Given this list of marker genes JPH4, OAT, GPR148, OR2D3, CASP3, OR12D3, OR10K1, OR2AP1, SPG11, OR56A5, OR13C6P, RAG1, ESPN, GALR2, MYO15A, FKBP1A, TMPRSS3, OR1L6, NR2F6, CLRN2, OR4P4, NRXN3, TAS2R50, TIFAB, GPR179, OR8U1, OR10J1, EYS, NMU, PRPH2, SYT10, OR2S2, NDRG4, CTNS, OR10X1, OR13C7, FKBP1B, OR4F6, B3GNT2, NLGN4Y, OR51C1P, OR2T12, OR52R1, OR8G1, PAX6, OR4N2, DAW1, OPN4, OMP, LGMN, FGF13, RGS16, SPAG16, PVALEF, OR14K1, BEST2, RGR, KAT2A, OR8U8, OR4C46, GMPPA, OR7D4, OR6B2, OR10AC1, CIC, VPS13B, PAX2, SLC24A1, GRIA1, BRSK1 (NCBI Gene Id 84446), CSMD1, FIG4, DCTN1, CHRNA5, OR6N1, RDH11, LARGE1 (NCBI Gene Id 9215), OR1S2, OR52M1, ASIC3, GNAT1, VN1R17P, CEBPA, OR1F12P, OR8J2, EFEMP1, CACNA1F, TNNI1, RAB3GAP1, SLC1A3, MANF, OR13C3, NPY2R, KCNK9, TENM4, OR56A4 (NCBI Gene Id 79271), SOD1, OR4K13, YTHDF1, HIF1A, KIAA0319, CLN3, CACNG2, FGFR1, OR11H2, ELMOD3, GPER1, CRX, OR6C6, GCH1, PIEZO2, OR2T35, DRD1, OR6C65, GRIN2A, OR9Q2, SCN4B, PCARE (NCBI Gene Id 388939), OR52A4P, AMFR, RBP3, ODAD4, NTRK1, ARR3, OR52E6, OR12D2, ALDH7A1, THRB, MECP2, CRYZ, OR6N2, NPAS4, FZD4, OR6Y1, OR4E2 (olfactory receptor family 4 subfamily E member 2), OR9G1, OR8A1, GSK3B, GRIN2B, SPG21, OR51B5, OR4F16, BLOC1S6, TIMM8B, POU3F4, RGS4, OR2B6, WHRN, ATXN7, MRGPRX2, C12orf57, HERC1, TAS2R46, OR5A2, SYNJ1, DNAAF3, KCNK4, OR7A5, OR5AR1, PRKAR2B, CHRNB4, ADRA2A, OR9A2, TUSC3, SLC52A3, MEF2C, OR52I2, NCMAP, OTOA, OR11L1, NDUFB9, RCAN2, TUBA1A, SCN4A, EIF4EBP2 (eukaryotic translation initiation factor 4E binding protein 2), OR52E2, NOS3, OR4A16, NTAN1, ITPR1 (NCBI Gene Id 619543), NCSTN, NXNL2, DNAJB6, GUCA1ANB-GUCA1A (GUCA1ANB-GUCA1A readthrough), GSTO1, ATF6, OR2W3, IGLON5, JPH3, TRPV1, SSH1, REST, OR4A4P, ARL6, PLCB2, S100B, OR56A3, OR51T1, UNC13B, CYP4V2, CRB2, GPI, PDC, DICER1, LOXHD1, KCNJ8, GABRB3, SHANK3, ITGB1, ADARB1, NSUN5, FGF12, OR2A12 (NCBI Gene Id 81432), ATP1A2, GPR155, REEP2, OR13C2, OR51Q1, OR5AU1, FAM161A, REEP6, ELP6, GRIN1, SLURP1, GJB4, TMEM108, RGS9 (regulator of G protein signaling 9), OR2T3 (olfactory receptor family 2 subfamily T member 3), DHRS3, OR5AS1, OR2V1, KCNMB4, ANKFN1, ACP3, CASQ1, CABP1, RPS6KA2, GJC1, KCTD16, OR2T10, MYO1A, OR14J1, OR4A8, GRIK2, OR2J2, BEGAIN, GNAT2, HMCN1, MYC, OR5H1, USH2A, SLC6A1, BRAF, DNAAF4, PIGR, TNFRSF1B, SCNN1A, DOP1B, HPS1, CA6, FZD2, ESPNL, OR5B12, SLC1A4, DRAM2, PPEF2, TMEM63B, DNAH9, NF1, TNR, OR14I1, SPX, KCNQ4, OR8U9, OR51E1, PHF24, OR2M3, PPP3CB, ADORA1 (adenosine A1 receptor), CABP4, OR6C75, ATPSCKMT, LILRB2, ALOXE3, OR4M2B, TAS2R20, GIP, NIPSNAP1, OR4A5, VLDLR (NCBI Gene Id 7436), PRKAR1B, CDKN2D, TAS2R16, ATP8A2, GLP1R, CHRM1, VAX2, C1QL1, USP53, TAS2R38, TMEM87A, KCNA1, TTC8, OR5A1, RP2, P2RX2, BLOC1S4, CPEB3, OR10Q1, HCN1, POU4F3, ACSS2, STAC, TRPA1, OR11G2, OR2T8, SPTBN4, CEP250, NGF, CNGA1, OR9K2, NBN, SLC38A8, P2RX7, OR56A1, CRTC1, OR5K3, OR2AT4, CRYGD, OR5T3, TMEM100, FOXB1, CALCA, OR4N4, ASCL1, TPPP, PTN, TTN, ROR1, LHCGR, MIR324, RASGRF1, TPBG, OR5M1, CCDC66, AARS1, OR10A3, CEBPB, CPLX4, ARMCX5-GPRASP2, OTOR, WFS1, PRKD1, SCN1B (NCBI Gene Id 6324), TSC1, NLGN4X, RP1, OR1C1, OR6M1, OR10G7, OR9Q1, PDE8B, NTF4, CRYGN, VSX1, CREB1, DRD3, OR4K3, AVP, HTR2A, OR14C36 (NCBI Gene Id 81451), OR4K1, LRIT1, OR5AK3P, GRK1, OR6C1, PPP1R9B, OR13J1, NTRK3, KBTBD13, EI24, POMK, PARD3, EFR3B, CCL2, OR8K1, ST3GAL4, LCN1, ARRB2, ITGA2, OR51H1, PROK2, ITGA3 (NCBI Gene Id 4454), PIRT, OR2W1 (olfactory receptor family 2 subfamily W member 1), RAC3, SLC4A10, HTR3E, TSHZ3, GRXCR1, CAMTA1, OR52N1, EGR2, NLGN1, OXT, ADORA2A, CEACAM16, CRYGA, ADGRF1, CCDC78, AAAS, NPTX2, OR5K4, OR3A2, GSK3A, CTNNA2, MFRP, HPN, OR4X1, RIMS2, WDR19, OR2D2, SARM1, OR11H6, OR6X1, HTT, RGS14, LRIG2, OR4E1, OR5M11, IGF1, P2RX1, OR10H1, LAMB2, TNF, JAKMIP1, GRM7, OR8K5, CNTN2, DEAF1, OR6V1 (NCBI Gene Id 81389), MGLL, TAS2R60, TPRN, TAS2R19, TYMP, DNAH11, OR5B2, OR5G3, OR4C45, OR2H1, OR5I1, USH1G, SLC7A11, WDR36, OR52P1, EIF4A3, PAFAH1B1, GLRA2, TMPRSS11E, OR2I1P, OR10D4P, ODAD3, MYH3, OR6C76, CHRNG, OR10AD1, AGER, SRF, CHRNB3, KCNQ1, SYNGAP1, RDH5, TAC4, OTOF (NCBI Gene Id 9381), OR52B6 (NCBI Gene Id 81269), GSG1L, OR11H7, TAS2R41, TNNT1, CHRNA10, OR6K6, BBS7, TMEM150C, OR4S1, OR5H2, OR1J2, EGFR, OR2L13, NTRK2, CACNG3, LPO, TCF15, MME, B3GAT1, BCR, OR5H6, GAA, OR7A17, PPT1, SIX6, OR4K15, ZFHX2 (zinc finger homeobox 2), OR10H5, HLA-DRA, HEXB, HOMER2, OR52B2, KIFC3, GNAS, OR8H2, CNGB1, VDAC3, ZNF385A, CNTNAP1 (contactin associated protein 1), OR9A4, OR5M9, OR5D14, RDH10, FZD9, CACNG4, HTR3A, AGTR2, OR6T1, PRCD, ARC, CLN8, TACR1, SLC29A1, OR2T27, TMIE, RDH8, OR5D16, CHRM5, ROCK2, PTK2B, TFAP2A, FBXO11, OR8S1, OR1S1, BFSP2, CAV3, CST2, STAC3, RTP3, OR4Q3, LMX1A, SLC24A4, NR2E3, EML2, NPAS1 (NCBI Gene Id 4861), OR2T11, OR14A16, CLIC5, ACE2, DMPK, OR2T33, OR52N4, CABP2, METTL23, MYO3A, UCN, SIX3, KCND2, DCANP1, EPHB2, OR6P1, ABCC8, FAM107A, CNTN5, OR2A1, NR4A3, OR10R2, TGFBI, OR13C8, SLC24A2, LDLR, ABCA4, OR3A3, OR52D1, AQP4, JHY, OPA1, DRD2, ARF4, APOE, OR1E2, OR10H4, POU4F2, OR5H8, CFAP221, OR10C1, OR3A1, TAAR9, OR13F1, OR6J1 (NCBI Gene Id 79549), OR1N2, CRYGB, OR52L2P, PAIP2, OR4K2, OR8G5, HOXB8, CRYAA, OR8B12, GUCY2F, OR11H1, EYA4, EPM2A, OR4D2, ADCY5, OR8D2, CRH, LHFPL3, CST4, NR2E1, OR2F1, TAFA2, MYO3B, OR1F2P, CELF4, OR2A5, CALHM1, DBH, COMT, OR13H1, ASIC5, OR52E5, OR1M1, BSND, CHRNA4, LEF1, OTOGL, OR52A5, MINAR2, BBS5, OR7A2P, SPATA7, CHL1, DTNBP1, S1PR2, CHRND, PITPNA, OR2T29, OR8B8, DVL1, MTMR2 (NCBI Gene Id 8898), STX4, CTSC, OPN1SW, TBL1X, CACNB4, RIC8B, OR51M1, FYN (FYN proto-oncogene, Src family tyrosine kinase), OR52I1, SCARB2, NTSR2, DDO, SCNN1B, GNG13, VPS13A, RGS9BP, CHRNA7, TAS2R14, OR8B4, OR2K2, OR4M2, SCNN1D, OR52E8, PDYN, ADRB2, OR5AC1, OR5K2 (olfactory receptor family 5 subfamily K member 2), CLN5, CUX2, NDP, FOXO6, OR52K2, PGAP1, CNGA4, CHD8, MPP2, OR4Q2 (olfactory receptor family 4 subfamily Q member 2 (gene/pseudogene)), CDC14A, STX1B, OR10G6, CRYBB3, HTR3C, OR8D4, SLC26A4, OR10K2, CFAP45, OR2B11, OR1L4, TAAR3P, TLX3, CRHBP, CDH23, CALB1, OR6F1, OR13G1, TNNC2, SCN1A, KERA, OR2B8P, STAC2, PRKCA, QKI, MGAT3, OR6K3, NDN, OR10J4, PDE6H, ADGRB3, SLC12A5, TAAR5, TUB, WDR47, CRYGC, NOB1, VN1R1, ADCY3, TACR2, RTP1, TAS2R9, NPFF, GJA3, GPX1 (glutathione peroxidase 1), RP1L1, OR2G6, PIP, CACNA1I, FOS, OR1D5, CCN3, SIX1 (SIX homeobox 1), ZIC2, OR8G2P, TRPV2, GET1, CLDN5, ACTN3, ADAM2, ATP2A1, EP300, OR10Z1, SELENON, OR1A2, TACO1, OR4C12, OR4K17, SGK1, PRKCG, CRYBG3, AOC2, SLITRK6, GM2A, OR10J6P, EYA1, AQP1, OR4M1, KCNJ10, SLC6A4, GRK7, OR2T5, LRRK2, DRGX, MYO7B, GATM, PDE1B, OR1I1, STX1A, PTEN, CDKN1B, HTR2C, FMR1 (fragile X messenger ribonucleoprotein 1), OR8B2, OR7C2, MC1R, OR10P1, KRAS, COL1A1, C14orf28, GBA1, PEX5, GLRA1, UBA5, FKRP, TMC2, TBR1, HTR3D, BORCS7, VN1R4, NRXN1, SNAI2, RAX, TAS2R7, OR8H1, OR51G1, CRYM, OR56B4, OR13C5, CHRNA6, CLRN3 (clarin 3), OR1B1, GPR158, ADGRD1, DDHD2, OR5AN1, LHFPL4, TNNC1, KIT, SYT4, OR10S1, OR52J3, OR2T2, SLC17A8, MMP24, ZMPSTE24, PBX3, OPN5, GNAT3, SNAP25, ITGA5, CALHM3, DDIT3, SCRN3, KCNJ11, HOMER1, OR6Q1, OR1E3 (NCBI Gene Id 8389), NPS, CST7, COL11A2, CDK5, GJA10, TNNT3, SRRM4, OR8B3, PSEN1, RCSD1, SLITRK4, OR5W2, ABL1, OR2L5, GJB2, TRIOBP, OR6C2, KCNE1, KLK8, OR2M4, NYX, CHRNB2, OR4C13, UNC119, ATP6V1B1, OR6C4, CYFIP1, GRID2, OR5C1, GLS, TIMM10, AGTPBP1, RGS21, OPRL1, LRIT3, RHO, CRYBB2, OR5M8, NRGN, NFATC4, SHANK2, OR13D1, OR4K14, OR4F3, BEST1, OR8J3, ROM1, GPR171, GRIN2D, KMT2A, SMR3B, OR10G4, OPRPN, OR2T34, PDE4A, SPECC1, SLC1A1, CFAP69, GRAP, OR51V1, TMTC4, TMEM98, SLC17A7, OR2A42, VN1R2, RELN, OPN1MW, GTF2A1L, OR4S2, PRKN, OR51B6, MAN2B1, GJD2, CHMP4B, TAS2R45, FEN1, DCAF11, ZNF488, OR5AK2, CAMK2N1, SEZ6 (seizure related 6 homolog), UGT2A1, PRRT2, RDH12, SERPINB6, TAS2R30, MEIS2, VN1R3, TAS2R8, RPGRIP1, SETD5, OR2AJ1, OR1L3, TMC7, EIF2AK3, TULP2, PRR4, RIC8A, OBP2B, TAC1, TMOD2, OR1E1 (NCBI Gene Id 8387), SFRP5, NHERF1, CHRNB1, ANO1, DIAPH3, INSR, LONRF2, OR8I2, HCRT, BACE1, OPRK1, BRINP1, AVPR1A, JAM2, FOXS1, HOXD1, OR51I1, EEA1, LCN2, TAS2R4, NTSR1, OR2C1, TSPEAR, MFSD8, MYH14, KCNK3, LCE1D, TBC1D24, OR52H1, OR7C1, RABGGTB (Rab geranylgeranyltransferase subunit beta), OR2L2, ELAVL4, TMEM25, OR2W6P, SCN9A, COCH (cochlin), OPN1MW2, AKT1, TIMM13, ZNF513, NRL, PDE6C (phosphodiesterase 6C), DNAAF11, GJC3, OR2AE1, OR14A2, CRYGS, OR2A14, AZGP1, OR4C3, OR51S1, SLC11A2, TACSTD2, OR2F2, OR7E24, MAPK1, SLC26A5, ANO9, PLEC, OR10W1, BAIAP2, SNCA, VTI1A, OR51B2, ABLIM1, MYCBP2, GRM1, CHMP2B, P2RX4, CWH43, HOXC10, GHSR, GLRA3, OR5V1, GNB1, CHM, PDZD7, ATP6V0A4, TULP1, SOX14, CRB1, OR4F29, RD3, TPP1, COMP, GRM8, DAG1, BARHL1, CRYBA2, WASF3, OR51G2, OR10H2, OR5M10, CDK18, NRXN2, CEMIP, SORCS3, OR52B4, ATXN1, OPA3, GMNC, OR2Z1, GUCA1B, RPGR, CHUK, APP, RTP4, OR4F21, MIR762, OR7A10, COL4A3, GPR88, LRRN4 (NCBI Gene Id 164312), EIF2AK4, OR4D1, NEFL, OR1L1, CD36, OR4A47, MKKS, GRIN3A, GABRR2, ASIC1, OR52K1, OR10A7, KCNQ3 (potassium voltage-gated channel subfamily Q member 3, NCBI Gene Id 3786), PAX3, INS, CHD7, OR9I1, OR1F1, OR4D10, COL6A1, OR52N5, OR9G4, GSX2, MBP, PDE6D, B2M, PDE6G, CACNG8, OR51A4, PIANP, OR8D1, TAS2R42, TAS1R1, OR13A1, CRYBA1, CDH3, OR5K1, GMFB, HTR3B, SLC6A3, MTNR1B, OR1Q1, LUM, OR5T2, CACNG7, PRDM12, AFF2, OPRM1, GPRASP3, GRPR, OR7G3, OR2M7, TAS2R40, OR6C68, RTL4, OR5H15, CLN6, FFAR4, OR10A5 (olfactory receptor family 10 subfamily A member 5), LHFPL5, RPL38, OR5L2, TAS2R43, OR4F15, OR51F2, SLC1A7, CARTPT, PLCB1, ABCC6, OR8H3, DGCR2, RTP5, RRH, SPRY2, OR11H12, OR6K2, OR2V2, OR51J1, SOBP, LRIG1, OR10G3, OR2M5, GIT1, ABCB1, DMD, OR2Y1, PAK5, PRNP, OR2AK2, LCTL, EN1, REM1, GRIN2C, OR4F4, EEF2, OR1D2, PAK6, OR6C74, RP9, WASHC4, BBS4, TMEM120A, MYO6, CACNB2, ANK3, OR10G9 (olfactory receptor family 10 subfamily G member 9), GSTM2, CCDC39, TAAR6, MIR455, UCHL1, TAS2R10, OR51L1, GUCA1A, OR4C15, OR51E2, IMPG1, PTGES, PPIP5K2, OR10T2, LINS1, AIPL1, ADGRV1, OR11A1, SLC2A4, BBS9, OR4D9, OR5J2, OR5H14, NOTCH1, OR5T1, OR7G2, TNNI2, OR5F1, OR10G2, OR10J5, MYO7A, GRIK5 (NCBI Gene Id 2901), PRKCZ, TRPM1, OR2B3, EPS8L2, OR56B1, OR4X2, NOG, GPRIN3, KCNK2, NAV2, ROGDI, NPR2, OR4F17 (NCBI Gene Id 81100), B4GALT2, CBR3, OR10H3, OR1K1, OR5B17, OR2B2, P2RX3, CHRNE, OR5AP2, ITGA8, RIMS1, OR9G9, OPN1MW3, GFY, EPAS1, TAS2R39, TAS1R3, NEUROG1, BIRC5, NPY1R, OR2AG2, IMPG2, TCAP, CST1, OR2T4, OR6C3, MAGT1, SPART, ATXN1L (ataxin 1 like), OR4L1, BBS2, CFAP43, BCHE, RPE65, OR4K5 (NCBI Gene Id 79317), CLRN1, TRPM8, PNKD, LRP2, KCNAB1, MDK, OR10A4, OR6S1, RCVRN, CCL11, OR4D5, TIMM9, VPS54, OR10AG1, GSDME, KCNA2, RORB, OR6A2, CCR2, ATP2B2, VDAC1, MIP, PLN, OR6C70, CXCL12, TAS1R2, OTOS, HIPK2, OR5BS1P, PGRMC1, SEMA5B, POU4F1, CFAP54, CACNA1D, MAPK3 (mitogen-activated protein kinase 3), ALDH1A3, PICALM, OR5D13, P2RX6, OR52Z1P, PPEF1, NEDD9, IGDCC3, IAPP, OPN1LW, SCN2A, DLL4, OR14L1, ADRA1A, RS1, NKX6-2, CCND2, MYH10, CLDN19, SERPINF1, TAS2R5, OR4A15, STRA6, OR12D1, NLGN3, RTP2, STRC, OR51D1, AXIN1, KRT12, ITGAX, OR2G3, RAB3A, PPP1R1B, OR1L8, WNT10B, CNGA2, COL11A1, GIGYF2, TREM2, OR5D18, MAPK8IP2 (NCBI Gene Id 51748), OR4D11, OR4F5, DCDC2 (doublecortin domain containing 2), RNF10, P2RX5, HMX3, TIMP3, OR1N1, CHRNA9, HEXA, BTBD9, CRYBB1, FSCN2, ATP8B1, OR51I2, SPNS2, TBX1, RABGGTA, DISC1, MFSD2A, SCN10A, ATAD1, OR1A1 (olfactory receptor family 1 subfamily A member 1), BGLAP, COL18A1, LRAT, EDNRA, PLK2, OR4B1, GJB6, NMB, SLC45A2, HMGCR, OR51F1, CCDC50, KCNMB3 (NCBI Gene Id 27094), OR52A1, C5AR1, LXN, DKK1, TAS2R31 (NCBI Gene Id 266664), OR5M3, THRA, TAS2R1 (taste 2 receptor member 1), TMC1, OR56B2P, OR13C9, OR11H4, ANKRD24, LPIN1, DRD5, OR5L1, SHISA7, PIAS1, PKD1L3, RCAN1 (regulator of calcineurin 1), SLC8A2, PDCL, CAMK4, PENK, PDE6B, OR52E1, SHANK1, PTCHD1, OR2A7, OR10A2, DIAPH1, OR13C4, MAG, VSX2, OR9A1P, SERPINE2, LAMC3, KAT2B, ABCA7, PNOC, TTBK1, SOX10, OR2W5P, CHRNA3 (cholinergic receptor nicotinic alpha 3 subunit), SLC8A3, CHRNA2, PTPRZ1, IRX5, OR2A2, SCNN1G, OR2J3, IFT20, MAPT, OR1P1, WNT7A, OR5B3, OR7D2, GBX1, ATP8A1, OR4N5, OR5AL1, PPP3CA, OR2A4, DLG4, PTPRQ, HOXD10, WDR1, OR4D6, CC2D1A, OR6B3, OR8K3, DNAJC19, OR52E4, OR2T7, OR8J1, OR1J1, MYH8, TTC36, GAREM2, HOXA1, OR4C16, RBP4, GLRB, NIPBL, OR51B4, OR5AC2, TLR2, OR10J3, TYR, TANC1, CLSTN2, MIR30B, FXN, GALR3, OR4C5, GHRL, GPR143, NEUROD2, HRH1, VPS35, PJA2, ABAT, OR7G1, EYA3, OR52N2, TAS2R13, OR51A2, CRYBA4, TNFRSF21, GRXCR2, RAX2, GNAL, ITPR3, RETREG1, GUCY2D, OR8U3, OR2AG1, ZNF212, EPHB1, DRD4 (NCBI Gene Id 1815), CNTNAP2, CCL3, SYT11, OR2M2, INSYN2A, TECTA, ZMYND8, OR52L1, JSRP1, CACNA2D4, OR2C3, OR10G8, TAFA4 (NCBI Gene Id 494553), RLBP1, SCN11A, OR2G2, SMR3A, FABP5, JAM3, OR1J4, OR2J1, STRIT1, FOXP2, INSYN1, BTG2, KATNIP, GRM6, OR10D3, POU6F2, BBS10, MIR342, RAPGEF3, OR2L8, KCNJ2, CACNG5, MET, NRCAM, PCDH15, KCNMB2, TAS2R3 (taste 2 receptor member 3), CNNM4, OR52W1, PKD2L1, PRRT1 (NCBI Gene Id 80863), USH1C, OR8G3P, TNNI3, MTOR, OR2T6, ADCY8, CNGB3, CHRFAM7A, OR5B21, GABRA5, GUCA1C, ZNF354A, OR2T1, SYNM, MYRF, PDE6A, OR4C6, OR10V1, OR1G1, S1PR1, CLCN1, BBS1, ELFN1, MYO9A, CBLN1, TH, HSP90AA1, GRM5, CNGA3, ADCY1, OR10A6, MYH7, OR51A7, CHRNA1, MAP1A, MUSK, SOD2, OR6B1, OBP2A, OR2A25, POMGNT1, MARVELD2, UBR3, CHMP4A (charged multivesicular body protein 4A), ARL6IP5, CPLX3, ASIC2, RIPOR2, OR2H2, CHST10, EPYC, OR2L3, NLGN2 (NCBI Gene Id 57555), PHOX2B, SHROOM4, PJVK, PKHD1L1, DMRT3, NETO1, COL2A1, OR1D4, OR4C11, ADNP, OR5P3, NRDC, OR5P2, here is a description of the gene set: studied in species Homo sapiens Human Gene Set: GOBP_NERVOUS_SYSTEM_PROCESS An organ system process carried out by any of the organs or tissues of the neurological system.